Given this list of marker genes Cirbp, Ttc3, Fgf13, Smad3 (SMAD family member 3), Zc3h12d, Cdkl3, Sfrp1, Mecp2, Hrg, Dab2, Cdkn2a, Smad4, Bcl11a, Cdk5, Epha7, Wnt11, Yy1, Adipor1, Cgrrf1, Sema6d, Fstl4, Gdf9, Sertad3, Pparg, Ip6k2, Trim46, Stk11, Agt, Hyal1, Cth, Naif1, Rgma, Serpine2, Nppa, Osgin1, Cgref1, Tchp, Dnajb2, Cdkn1a, Rerg, Psrc1, Vgll4 (NCBI Gene Id 232334), Dnajc2, Cdkn1b, Ulk1, Slit1, Dcbld2 (discoidin, CUB and LCCL domain containing 2), Ppara (NCBI Gene Id 399624), Rtn4r, Sox17, Dcstamp, G6pd2, Sh3bp4, Cfl1, Inhba, G6pdx, Tomm70a, Hspa1a, Ppard (peroxisome proliferator activator receptor delta), Slit2, Cdh1, Cav3, Bst2, Hnf4a, Wnt3a, Gsk3a, Rgs2 (regulator of G-protein signaling 2), Sesn1, Acvrl1, Sema6c, Mndal, Smarca2 (SWI/SNF related, matrix associated, actin dependent regulator of chromatin, subfamily a, member 2), Ptprs, Cdkn2d, Tnr, Draxin, Ppp1r9b, Msx1, Slit3, Wt1, Ddx3x, Brca1, Zfp418, Mt3, Prdm11, Rrad, Tmem196, Bmpr2, Cda, Plxna3, Tgfb1, Adipor2, Dcun1d3, Pten, Dab2ip (NCBI Gene Id 98996), Ndufs3, Arhgap4, Frzb, Sema3g, Sema3f, Hspa1b, Bcl6, Ostn, Sema4f, D7Ertd443e, Nf2 (NCBI Gene Id 18016), Rgs4, Rbbp7, Cyp27b1, St7l, Rack1, Hyal2, Sertad2, Sfrp2, Prdm4, Ctdp1, Map2, Ei24, Ccn3, Gas1, Nppb, Wnt3, Eaf2 (NCBI Gene Id 106389), Sesn2, Minar1, Ppt1, Osgin2, Dip2b, Pi16, Eno1, Cryab, Grem1, Tnk1, Ulk2, Bmp10, D1Pas1, Gng4, Rb1, Enpp1, Bcl2, Rtn4, Ccr5, Pml, Adam15, Pak1, Spart, Ndufa13, Cdkn2aip, Atg16l1, Acvr1b, Wnt5a, Zmat3, Sema5a, Phb1, Cdhr2, Bdkrb1, Fhl1, Bbc3, D130043K22Rik, Trim40, Sema3a, Ccdc85b, Nrp1, Tro, Mul1, Myl2, Foxk1, Foxp1, Sertad1, Cdkn2c, P3h1, Ifrd1, Tgfb2, Tspyl2, Ryk, Nme6, Fbp1, Sphk2, Gdf2, Ntn1, Spag9, Ccar2, Gja1, Trp53, Dact3, Ahsg, Smarca4, Hdac6, Crlf3, Ptprj, Mag, Caprin2, Actr3, Eno1b, Rnf6, Rbm10, here is a description of the gene set: Mouse Gene Set: GOBP_NEGATIVE_REGULATION_OF_CELL_GROWTH species: Mus musculus Any process that stops, prevents, or reduces the frequency, rate, extent or direction of cell growth.